Given this list of marker genes FOXO4, ADM, MIR199B, ITGA8, NFATC3, MRTFA, RAMP2, WNT4, MIR145, NOTCH1, HEY1 (NCBI Gene Id 23462), MESP1, NPNT (nephronectin), PDGFB, PRDM6, SRF, SIRT1, MIR18A, DNMT1, SIX1, RCAN1, GATA6, MECP2, APLNR, ZEB1, HES1 (NCBI Gene Id 3280), MIR221, EREG, HEY2, MEF2C, GPER1, MIR22, MIR125B1, EDNRA, NOTCH4, TBX18, SMARCD3, PIAS1, MIR15B, MYOCD, FGFR2, SOX9, VEGFA, RBPMS2, SOD2, NFATC1, TBX3, TBX2, MIR424, FGF9 (NCBI Gene Id 2254), MIR140, KIT, MRTFB, MIR34A, MIR26A1, NFATC2, FOXF1, EDNRB, BMP4, NFATC4, MIR21, CTNNB1, FGF10, NOTCH2 (notch receptor 2), EFEMP2, MED28, CTH, MIR1-1, TGFB1, COMP, SHH, TMEM204, QKI, PITX2, PDCD4, ACVR1, MIR100, SGCB, ENG (endoglin), OLFM2, here is a description of the gene set: studied in species Homo sapiens The process in which a relatively unspecialized cell acquires specialized features of a smooth muscle cell; smooth muscle lacks transverse striations in its constituent fibers and are almost always involuntary. Human Gene Set: GOBP_SMOOTH_MUSCLE_CELL_DIFFERENTIATION